Given this list of marker genes FCGR2B, PRKACA, FCN2, IL2RG, ANO6, APPL2, C3, FCGR2A, MYO18A, ATG3, TULP1, ADIPOQ, MBL2, IL2RB, FCGR2C, RAP1A, SIRPG, RACK1, HMGB1, PLSCR1, SYK, BTK, SOD1, TREM2 (triggering receptor expressed on myeloid cells 2), ITGAV, FCN3, NCKAP1L, C2, COLEC11, CD36, SFTPD, ALOX15, MIR20A, PRTN3, FGR, ABCA7, CD47, FCER1G, APOA1, SYT7, GATA2, CNN2, CSK, ITGA2, PRKCG, AZU1, TLR2, SYT11, HCK, LMAN2, SCARB1, F2RL1, PIP4P2, ATG5, RAB27A, TGM2, PTPRJ, SPACA3, ARAP1, SLC11A1, STAT3, IL15RA, TGFB1, CYBA, RAP1GAP (RAP1 GTPase activating protein), FPR2, SNX3, CCL2, CFP, SPHK1, SIRPA, CAMK1D, CD300A, C4B, PTPRC, TUB, LYAR, AHSG, MERTK (NCBI Gene Id 10461), CLEC7A, PYCARD, PLCG2, CD300LF, MIR181B1, FCGR1BP, IFNG, FCGR1A, LETMD1, MIR183, MIR17, APOA2, RAB31 (RAB31, member RAS oncogene family), FCN1, GAS6, DYSF, BCR, PTX3, STAP1, COLEC10, CALR, DOCK2, PLA2G5, C4A (NCBI Gene Id 720), IL15, APPL1, SIRPB1, here is a description of the gene set: Any process that modulates the frequency, rate or extent of phagocytosis, the process in which phagocytes engulf external particulate material. species: Homo sapiens Human Gene Set: GOBP_REGULATION_OF_PHAGOCYTOSIS